The following is a description of a gene set: species: Mus musculus Mouse Gene Set: JOHANSSON_BRAIN_CANCER_EARLY_VS_LATE_UP from publication Johansson FK, Göransson H, Westermark B (PMID 15750623) Genes up-regulated in early vs late brain tumors induced by retroviral delivery of PDGFB. Retroviral tagging previously identified putative cancer-causing genes in a mouse brain tumor model where a recombinant Moloney murine leukemia virus encoding the platelet-derived growth factor B-chain (MMLV/PDGFB) was intracerebrally injected in newborn mice. In the present study, expression analysis using cDNA arrays revealed several similarities of virus-induced mouse gliomas with human brain tumors. Brain tumors with short latency contained on average 8.0 retroviral insertions and resembled human glioblastoma multiforme (GBM) whereas long-latency gliomas were of lower grade, similar to human oligodendroglioma (OD) and had 2.3 insertions per tumor. Several known and novel genes of tumor progression or cell markers were differentially expressed between OD- and GBM-like tumors. Array and quantitative real-time PCR analysis demonstrated elevated expression similar to Pdgfralpha of retrovirally tagged genes Abhd2, Ddr1, Fos, Ng2, Ppfibp1, Rad51b and Sulf2 in both glioma types compared to neonatal and adult normal brain. The retrovirally tagged genes Plekhb1, Prex1, Prkg2, Sox10 and 1200004M23Rik were upregulated in the tumors but had a different expression profile than Pdgfralpha whereas Rap1gap, Gli1, Neurl and Camk2b were downregulated in the tumors. The present study accentuates the proposed role of the retrovirally tagged genes in PDGF-driven gliomagenesis and indicates that insertional mutagenesis can promote glioma progression., and this is the list of marker genes: Adm, Dnah5, Usp29, Fos, Tacc3 (NCBI Gene Id 97263), Racgap1, Rrm2